Given this list of marker genes INO80B, LINC01816, PRADC1, DOK1, ENSG00000294870, FAM136A, ALMS1, C2orf42, LINC01888, GKN2, HMGN2P21, TTC31, RPL39P15, ACTG2, NAT8, CCT7, C2orf81, RN7SL160P, C2orf78, BOLA3-DT, CD207, RPS28P5, RTKN, PCYOX1, WDR4P2, ENSG00000286739, ALMS1P1, GKN3P, FBXO41, OR7E46P, APLF, ANTXR1, AAK1, RNU6-542P, BMP10, SNORA36C, NFU1, SNRPG, EGR4, RNA5SP96, GKN1, CLEC4F, ANXA4, RNU6-1216P, LINC01143, PCGF1, RPL23AP92, DYSF, RAB11FIP5, GMCL1, OR7E62P, ENSG00000287687, VAX2, ATP6V1B1 (NCBI Gene Id 525), RN7SL470P, ALMS1-IT1, HTRA2, NAGK, DUSP11 (dual specificity phosphatase 11), EMX1, SMANTIS, DQX1, RPSAP28, TOR1BP1, HMGA1P8, FIGLA, MIR1285-2, DCTN1-AS1, ARHGAP25, PROKR1, TGFA, M1AP, LBX2-AS1, AUP1, MRPL36P1, TAF13P2, FNBP1P1, MCEE, SEMA4F, ATP6V1B1-AS1, RNU2-39P, PCBP1-AS1, MPHOSPH10, ANKRD53, RNU6-111P, B3GALNT1P1, PCBP1, LBX2, WDR54, ENSG00000212378, KRT18P26, ADD2, TLX2, DGUOK, TIA1, CYP26B1, BRD7P6, FBXO48, MOB1A, TGFA-IT1, RNU6-105P, SPR, STAMBP, SLC4A5, LINC01890, DCTN1, MIR3126, TPRKB, RN7SL604P, GFPT1, OR7E91P, MOB4P1, RPS20P10, TET3, RPS15AP13, SMYD5, ZNF638, SNRNP27, RPL36AP16, ENSG00000287435, TVP23BP2, BOLA3, INO80B-WBP1, WBP1, ENSG00000286244, ASPRV1, ENSG00000228384, ELOCP21, TEX261, PAIP2B, MOGS, MRPL53, MTHFD2, CCDC142, RNA5SP97, NECAP1P2, SFXN5, NOTO, EXOC6B, NAT8B, MXD1, DGUOK-AS1, LOXL3, here is a description of the gene set: Human Gene Set: chr2p13 studied in species Homo sapiens